The following is a description of a gene set: studied in species Homo sapiens Human papillomaviruses (HPV) are associated with nearly all cervical cancers, 20% to 30% of head and neck cancers (HNC), and other cancers. Because HNCs also arise in HPV-negative patients, this type of cancer provides unique opportunities to define similarities and differences of HPV-positive versus HPV-negative cancers arising in the same tissue. Here, we describe genome-wide expression profiling of 84 HNCs, cervical cancers, and site-matched normal epithelial samples in which we used laser capture microdissection to enrich samples for tumor-derived versus normal epithelial cells. This analysis revealed that HPV(+) HNCs and cervical cancers differed in their patterns of gene expression yet shared many changes compared with HPV(-) HNCs. Some of these shared changes were predicted, but many others were not. Notably, HPV(+) HNCs and cervical cancers were found to be up-regulated in their expression of a distinct and larger subset of cell cycle genes than that observed in HPV(-) HNC. Moreover, HPV(+) cancers overexpressed testis-specific genes that are normally expressed only in meiotic cells. Many, although not all, of the hallmark differences between HPV(+) HNC and HPV(-) HNC were a direct consequence of HPV and in particular the viral E6 and E7 oncogenes. This included a novel association of HPV oncogenes with testis-specific gene expression. These findings in primary human tumors provide novel biomarkers for early detection of HPV(+) and HPV(-) cancers, and emphasize the potential value of targeting E6 and E7 function, alone or combined with radiation and/or traditional chemotherapy, in the treatment of HPV(+) cancers. from publication Pyeon D, Newton MA, Lambert PF, den Boon JA, Sengupta S, Marsit CJ, Woodworth CD, Connor JP, Haugen TH, Smith EM, Kelsey KT, Turek LP, Ahlquist P (PMID 17510386) Human Gene Set: PYEON_CANCER_HEAD_AND_NECK_VS_CERVICAL_DN Down-regulated genes in head and neck cancer compared to cervical carcinoma samples., and this is the list of marker genes: ASPRV1, KLK8, MEGF10, H19, EIF1AY, S100A7A, CDSN, IL1R2, RPS4Y1, SLC6A15, KRTDAP, DDX3Y, FEZ1, DPT, LY96, ZFY, CRISPLD1, TXLNGY, DEFB4A, MAGEA12, KLK7, USP9Y, NEB, KDM5D, DCN, PDPN, DSC1, ADGRV1, LRRC15